Given this list of marker genes OSBPL10, MBOAT2, LPCAT4, OSBPL5, OSBPL8, MBOAT1, LPCAT3, PLA2G2F, PLA1A (phospholipase A1 member A), here is a description of the gene set: Remodeling the acyl chains of phosphatidylserine, through sequential deacylation and re-acylation reactions, to generate phosphatidylserine containing different types of fatty acid acyl chains. Human Gene Set: GOBP_PHOSPHATIDYLSERINE_ACYL_CHAIN_REMODELING species: Homo sapiens